The following is a description of a gene set: The series of molecular signals initiated by a ligand binding to a vascular endothelial growth factor receptor-2 (VEGFR-2) on the surface of a target cell, and ending with the regulation of a downstream cellular process, e.g. transcription. Mouse Gene Set: GOBP_VASCULAR_ENDOTHELIAL_GROWTH_FACTOR_RECEPTOR_2_SIGNALING_PATHWAY species: Mus musculus, and this is the list of marker genes: Kdr, Slc31a1, Pdcd6, Dab2ip (disabled 2 interacting protein), Clec14a, Vegfa